The following is a description of a gene set: A process in which force is generated within smooth muscle tissue, resulting in a change in muscle geometry. This process occurs in the urinary bladder. Force generation involves a chemo-mechanical energy conversion step that is carried out by the actin/myosin complex activity, which generates force through ATP hydrolysis. The urinary bladder is a musculomembranous sac along the urinary tract. Mouse Gene Set: GOBP_URINARY_BLADDER_SMOOTH_MUSCLE_CONTRACTION species: Mus musculus, and this is the list of marker genes: P2rx2, Pla2g6 (NCBI Gene Id 53357), Trpa1, Cacna1c, P2rx3, Trpv1, Tacr1, Kcnma1, Htr2a, Htr7, Ptger3, Atp2b4